The following is a description of a gene set: Human Gene Set: HP_NEPHRONOPHTHISIS species: Homo sapiens Nephronophthisis Presence of cysts at the corticomedullary junction of the kidney in combination with tubulointerstitial fibrosis., and this is the list of marker genes: DYNC2I2, ZNF423, FAN1, NPHP4, IFT43, TMEM138, DYNC2I1, CEP290, GLIS2, WDR19, KIAA0753, IQCB1, DCDC2, TTC21B, INVS, TMEM67 (transmembrane protein 67), CEP120, TMEM216, IFT172, ANKS6, CEP164, SDCCAG8, CEP83, NPHP1 (nephrocystin 1), TRIP11, IFT140, AHI1, NEK8, TRAF3IP1, DYNC2LI1, RPGRIP1L, DYNC2H1, CEP41, IFT80, NPHP3, XPNPEP3, MAPKBP1